Given this list of marker genes Tprkb, Osgep, Osgepl1, Gon7, Yrdc, here is a description of the gene set: Mouse Gene Set: GOBP_TRNA_THREONYLCARBAMOYLADENOSINE_MODIFICATION species: Mus musculus The attachment of a carbonyl group and a threonine to the amino group of the adenine residue immediately 3' of the anticodon, in tRNAs that decode ANN codons (where N is any base).